The following is a description of a gene set: species: Homo sapiens Human Gene Set: REACTOME_PTK6_PROMOTES_HIF1A_STABILIZATION PTK6 promotes HIF1A stabilization, and this is the list of marker genes: HBEGF, LRRK2, PTK6, HIF1A, EGFR, GPNMB